The following is a description of a gene set: from publication Chen Y, Wang X (PMID 31504780) studied in species Homo sapiens Human Gene Set: MIR103A_1_5P Genes predicted to be targets of miRBase v22 microRNA hsa-miR-103a-1-5p in miRDB v6.0 with MirTarget v4 prediction scores > 80 (high confidence targets)., and this is the list of marker genes: ZNF180, KDF1, EOGT, EXO1, HEXIM1, MCL1, ZNF711, DPYS, HCFC2, TMIE, ABHD10, CDH12, FAM174A, SESN1 (NCBI Gene Id 27244), ZFP91, CRACD, DYRK1A, UST, STRIP1, GPR82, BLCAP, CYLD, VAV3, XIAP, OGG1, MBNL2, KPNA7, ZNF827, NRAS, LURAP1L (NCBI Gene Id 286343), SON, TMEM200B, ABL2, SEMA5A, ARMH4, SPON1, ESR1, UBE4B, TMEM108, MAB21L2 (mab-21 like 2), DAO (NCBI Gene Id 1610), SGCD, UBE2A (NCBI Gene Id 7319), COMMD3-BMI1, SLC28A1, MTMR1, NAA50, HHLA1, RAB21, UBR3, AFF1, PPFIA4, CPEB3 (cytoplasmic polyadenylation element binding protein 3), CCPG1, SPOCK3, TNPO1, MAN2A1, NSD1, LILRB3, G3BP2, DUSP3, PLXDC2, IL36G, CNNM2, BBX, DLL1, DACH1, IGF2R, TMEM154, NR3C1 (NCBI Gene Id 389335), BAG4, SCN2A, SLC8A1, SLC46A2, PLAGL1, MAGI3, BARD1, DNAL1, ERVV-1, SMAD2, TNRC6B, EPHB1, MGA, ZNF236, EIF2AK4, CDK6, NFXL1 (nuclear transcription factor, X-box binding like 1), LYST, OXTR (NCBI Gene Id 5021), LIFR, ONECUT2, SLC38A2, RGL1, ABCC9, GLO1, RBAK, DNM3, SYNM, LGI2, PXYLP1, OPN5, FXR1, SEC24A, SRSF1, DNAAF9, FAT3, RALA, C5orf24, FBXO45, MKRN1, CCL23, CARD8, MTF2, CHGB, PAK2, TAF7, RHEB, MOSMO, USP31, ITGA8, JPT1, NRXN1, EPS8, TADA2B, MITD1 (microtubule interacting and trafficking domain containing 1), TBCA, RBM27, ATP6V0D1, G3BP1, ZHX1, BCL6B, CDH11, TCEAL9, TRAPPC13, NGEF, KMT2A, TENM1, LARP4, RSPO3, CYLC2, VPS35L, ELOVL6, EPHA4, IFT80, MAGI1, HAUS6, PALM2AKAP2, GXYLT1, SLC9A8, APBB2, LRATD1, CSTA